Given this list of marker genes Shank3, Apoe, Nlgn1, Reln, Nrxn1, Htr1a (NCBI Gene Id 15550), here is a description of the gene set: The receptor clustering process in which N-methyl-D-aspartate (NMDA) receptors are localized to distinct domains in the cell membrane. studied in species Mus musculus Mouse Gene Set: GOBP_NMDA_GLUTAMATE_RECEPTOR_CLUSTERING